Given this list of marker genes LCLAT1, CRTC1, CTNNA2, CAPRIN1, MED9, ACVR2B, STON2, MAN2A2, VPS53, RNF125, ALCAM, PSG1, PSG4, GLCCI1, BCL11A, CEP85, PDGFB, CLSTN1, SLC25A30, TLNRD1, GAB2, AHDC1, RGP1, DUSP7, TTC33, MAP3K13, RFX3, LARP1, DCAF10, PSG7, GRAMD1B, EPHA7, NUDT16, ASPH, OPA3 (outer mitochondrial membrane lipid metabolism regulator OPA3), FMR1, SERP2, CRIM1, MLEC, UBE3A, ZNF516, DMD, SDK2, CEMIP, CSMD2, MLXIP, MFSD6, RBSN, CSMD3, BCL11B, FZD3, ZNF608, PBX2, TECPR2, SUPT3H, FGD6, PLEKHG7, PBX1, TCEANC2, KIF1B, N4BP3, RP9, SCN4B, CBX6, NOTCH2NLA, CHP1, RPRD2, EPHB2, TRABD2B, AKTIP, MRPL15, TC2N, TBC1D7, HSBP1, GCNA, TDRKH, AADAT, PRR15L, PSG8, ANKRD20A3P, CHRM1 (cholinergic receptor muscarinic 1), ISYNA1, CAPZA1, GALK2, NUP214, here is a description of the gene set: from publication Chen Y, Wang X (PMID 31504780) studied in species Homo sapiens Genes predicted to be targets of miRBase v22 microRNA hsa-miR-4722-3p in miRDB v6.0 with MirTarget v4 prediction scores > 80 (high confidence targets). Human Gene Set: MIR4722_3P